Given this list of marker genes Cln6, Pum1, Serpinf1, Nr1d1, Calb1, Camk2n1, Auts2, Arrb2, Lsamp, Astn1, Shank3, Oprk1, Nms, Ins1, Kalrn, Wdr47, Crh, Aprt, Slc1a3, Abcc1, Arl6ip5, Ciart, Brsk1, Sod1, Oxr1, Calca, Sgip1, Fxr1, Lypd1, Nr1d2, Trpv1, Alb, B2m, Ager, Tpgs1, Dach1, Amfr, Lgi4, Apba2, Igf1, Taar4, Pafah1b1, Trem2, Myo15a, Prkcz, Strn, Nog (noggin), Ncor1, Slc24a2, Tafa2, Bbs12, Htra2, Nfatc4, Slc18a2, Ptger4, Eif4ebp2, Syt4 (NCBI Gene Id 20983), Slitrk5, Agtr1a, Kcnq3, Fgf2, Bsx, Avp, Nf1, Bbs1, Chat, Syngap1, Fmc1, Pak5, Shh, Sptbn2, Borcs7, Acvr2a, Prkcg, Cstb, Id2 (inhibitor of DNA binding 2), Cln3, Ncstn, Bglap2, Mir96, Camk4, Plk2, Rmi1, Scn11a, Slitrk1, Slc10a4, Kat2a, Slc17a7, Helt, Enpp1, Hexb, Fbxl20, Hrh1, Sts, Rgs14, Zfx, Adarb1, Slc1a1, Slc8a3, Lmo3, Grik1, Ephb2, Otog (NCBI Gene Id 269917), Htr1d, Adam2, Ntrk1, Lgmn, Cacna1e, Foxb1, Reg2, Dnaaf4, Pde8b, Abat, Aff2, Mc1r, Alk, Thra, Celf6, P2rx3, Npy5r, Gaa, Brinp3, Penk, Mir133a-1hg, Lep, Slc2a4, Pax5, Park7, Tal1, Adcy5, Pten, Gabrg2, Zfhx2, Pla2g6 (phospholipase A2, group VI), Klk8, Aplp2, Tacr1, Bcl2, Sgsh, Ccl11, Csnk1e, Pde5a, Etv1, Btg2 (NCBI Gene Id 98237), Chl1, Nkx2-1, Mef2c, Mecp2, Man2b1, Minar2, Ormdl1, Ptpn5, Reln, Ins2, Adrb2, Mup4, Abcc8 (ATP-binding cassette, sub-family C member 8), Mapt, Epm2a, Ctnnd2, B3gat1, Shank1, Klk14, Specc1, Negr1, Elp6, Shank2, Cln8, Fmr1, Mdga2, Cartpt, Psap, Homer2, Napepld, Nts, Glra1, Esr2, Zic1, Adcy3, Mtor, Gdf15 (NCBI Gene Id 23886), Nipal3, Gnaq, Clstn3, Mfsd2a, Ankrd26, Spire1, Grm2, Kcnd2, Nrxn1, Hand2, Axin1, Dgki (diacylglycerol kinase, iota), Hoxd10, Ghrh, Adh1, Gbx1, Neurog1, Brinp2, Casp3, Gba1, Apoe, Lonrf2, Ddhd2, Ptger3, Hmgcr, Atp6v1b1, Lrrtm1, Akt1, Pias1 (protein inhibitor of activated STAT 1), Srf, Efr3b, Git1, Cntnap2, Ubr3 (ubiquitin protein ligase E3 component n-recognin 3), Slc7a11, Rps6kb1, Cck, Slc8a2, Dbn1, Gabrb3, Pyy, Il1rn, Pak6, Hdac2, Mrgpra3, Tmbim4, Epha4, Hprt1, Homer1, Usp46, Eps8, Braf, Fzd9, Prnp, Crbn, Mme, Crebbp, Ep300, Tsc2, Ace2, Lamb1, Sez6l2, Cx3cr1, Gnb1l, Grp, Kirrel3, Foxp2, Grm7, Tac1, Septin5, Jun, Gip, En1, Insr, Cacna1b, Mfsd8, Cdk5, Iglon5, Gmppa, Npy, Adcy1, Dcdc2a, Ppp1r9b, Cxcl12, Hcrtr2, Chrna3, Adcyap1, Tmem18, Atp1a2, Atp8a2, Chrnb1, Scn1a, Gpr52, Mrap2 (NCBI Gene Id 640967), Npas1, Adora1 (NCBI Gene Id 98749), Dgat1, Qrfp, Derl2, Scn8a, Chd7, Abl1, Kmt2a, Adora2a, Pbx3, Meis2, Hcrtr1, Scn10a, Ar, Clcn3, Bcl7a, Lhx1os, Lrrn4, Pln, Oxtr (oxytocin receptor), Ncoa1, Hcn1, Aph1c, Lepr, Vps13a, Gls, Ric8a, Hif1a, Cpeb3, Zfp385a, Abtb3, Glp1r, Ttbk1, Il1b, Cacna1a, Grm1, Glud1, Gpr37, Dbh, Snap25, Cacnb4, Rogdi, Pirb, Tuba1a, Bhlhb9, Prrt1, Osm, Ntf5, Gng7 (guanine nucleotide binding protein (G protein), gamma 7), Agtr2, Gpi1, Guca2b, Ppt1, Olfm2, Gli3, Arf4, Nhlh2, Ghrl, Zzef1, Npw, Naglu, Fen1, Aaas, Ndp, Synpo, Fzd4, Tacr3, Meis1, Retn, Ube3a, Ankfn1, Cpt1a, Tifab, Dmrta1, Kcnq1, Rcan1, Prex2, Thbs4 (thrombospondin 4), Ckap5, Pax6, Vmn2r116, Aldh1a7, Dcaf11, Npb, Kcnk2, Oprl1, Tgm4, Nptx2, Dctn1, Ctns, Atp1a3, Oprd1, Pmp22, Agt, P2ry1, D130043K22Rik, Chrna4, Ahi1, Npc1, Tshr, Lrrk2, Als2, Chrnb2, Gpr171, Inpp5f, Gnat1, Ap1s2, Ift88, Per3, Crebrf, Mup20, Agrp, Lhx8 (LIM homeobox protein 8), Vps13b, Syt11, Ext1, Pirt, Drd4, Mdk, Stra6, Mrgprx1, Nlgn1, Slc22a5, Grik2, Kctd16, Ptchd1, Prlhr, Six3, Myo6, Slc6a1, Dmrt3, Chrd, Ada, Shisa7, Gabra5 (NCBI Gene Id 319559), Cic, Grin2b (glutamate receptor, ionotropic, NMDA2B (epsilon 2)), Mup5, Stat3, Kcna2, Cacna1c, Klhl1, Mta1, Ednrb, Sptbn4, Bloc1s6, Plcb1, Gpr39, Dlg4, Zfhx3, Dtnbp1 (NCBI Gene Id 94245), Nmur2, Ppp1r1b, S100b, Ptgs2, Chd8, Mc4r, Mcoln3, Atp2b2, Ndrg4, Gigyf2, Vip (vasoactive intestinal polypeptide), Fuom, Fadd (Fas associated via death domain), Glrb, Gpr176, Eif2ak4, Efnb3, Opn4, Strbp, Rag1, Gpr88, Abi2, Tanc1, Psen2, Abhd12, Rptor, Atp7a, Cc2d1a, Ttc21b, Mmp17, Drd5, Uts2r, Trpm7, Ankrd11, Rnf170, Foxa2, Dpp4, Htr2c, Jph4, Neto1, Mir23a, Slurp1, Fgfbp3, Ace, Abl2, Hdac4, Psen1, Picalm, Pcdh15, Nr4a3, Abca2, Mup1, Th, Sncg, Ube2q1, Ptprz1, Aoc3, Scn3a, Gjb4, Fosb, Vdac1, Paip2, Tlr2, Fgf14, Egr1 (early growth response 1), Fign, Itpr3, Slc4a7, Ptn, Npas3, Crhr2, Cux2, Pcm1, Trpc2, Taco1, Gfral, Pdcd10, Bbip1, Fosl1, Slc6a4, Foxo6 (forkhead box O6), Chrna5, Svs3a, Nrg1, Mafg, Adgrf1, Ppara, Bc1, Pianp, Dvl1, a, Pcdh17, Myo5a, Pgr, Comt, Hoxd9, Grm6, Hcrt, Grcc10, Pex13, Gad1, Musk, Pde4d, Unc79, Cyp11b2, Oprm1 (opioid receptor, mu 1), Sct (NCBI Gene Id 20287), Atp1b2, 2510009E07Rik, Rxfp4, Dmbx1, Egr2, Slc16a1, Creb1, Sez6, Rapgef3, Kat2b, Pja2, Idua, Scn9a, Gprin3, Vps54, Pmch, Trmt1l, Etv5, Cort, Mup3, Agtpbp1, Nrxn3, Asic4, Cntn1, Pfkfb3, Rin1, Drd1, Ldlr, Nr4a2, Gria1, Dbi, Agrn, Trp53, Gm2990, Nav2, Dkk1, P2rx4, Kcnq2, Sez6l, Iapp, Slc1a2, Dmd, Apba1, Rnf180, Vps35, Grin1, Adcy8, Clstn2, Aph1b, Ntan1, Itga5, Ptgs1, Csf2, Crhbp, Adam22, Nrxn2, Dnah11, Vwa1, Tmem74, Ntsr1, B4galnt1, Cntfr, P2rx2, Eif4g1, Hoxa1, Aldh1a3, Kcnj10, Trpm4, Fkrp, Csmd1, Gm527, Grid1, Aim2, Gla, Ncoa2, Sdk1, Ahcyl, Nps, Ddo, Slc25a46, Gfi1, Tmod1, Pou4f1, Gucy2d, Itgb1, Ido1, Selenop, Cdh23, Fgf13, Snca, Adm2, Insl5, Prlh, Npy2r, Cfap20, Vdac3, Nr3c1, Grin2d, Uba6, Gcnt4, Gnao1, Parp1, Nlgn3, Lmx1a, Pde1b, Kras, Nlgn2, Nptn, Aldh2, Abca7, Nr2e1, Npas4, Nedd9, Gpr83, Ntrk2, Apln, Abcb1b, Mup2, Runx1, Ift20, Slc4a10, Mup11, Fshr, Hexa, Atxn1l, Pitx3, Slc12a5, Dab1 (disabled 1), Uchl1, Bbs4, Casp1 (NCBI Gene Id 12362), Esp22, Fezf2, Grn, Lcn2, Dynlrb1, Jph3, Npy1r, Eif4e, Fig4, Adrb1, Adra1b, Ngf, Rcan2, Grm4, Deaf1, Htt, Col6a1, Ccnd2, P2rx1, Git2, Bglap, Npsr1, Prkaa1, Cnp, Cnr1, Cyp11a1, Bace1, Serpine2, Thbs1, Hrh3, Ahcy, Tmod2, Ghsr, Spg21 (SPG21, maspardin), Capn2, Srpx2 (sushi-repeat-containing protein, X-linked 2), Tsx, Bdnf, Atg7, Ncam1, Asic1, Slitrk6, Atp8a1, Wfs1, Bahcc1, Chrna7, Cckar, Tpbg (trophoblast glycoprotein), Baiap3, Ndufs4, Bche, Tnr, Cntnap4, Morc1, Phf21a, Nos1, Tbr1, App, Sod2, P2ry2, Prkar1b, Ptgds, Grm5, Zmpste24, Gal, Cend1, Prl, Dscam, Cntn2, Nlgn4l, Itga3 (NCBI Gene Id 16400), Esp1, Sorcs3, Oxt, Crhr1, Kcnab1, Prkn, Met, Acss2, Synj1, Kit, Myh14 (NCBI Gene Id 71960), Cyp7b1, Htr6, Ghrhr, Drd2, Ythdf1, Mbd5, Htr2b, Sobp (NCBI Gene Id 78400), Taar5, Nmu (NCBI Gene Id 56183), Kcnip3, Ren1, Fxn, Ppy, Hoxb8, Cwh43, Celsr1, Atxn3, Htr7, Ucn, Fto, Pgrmc1, Crtc1, Gpr157, Tspo (translocator protein), Ceacam2, Itga8, Gng8, Lpar5, Gnat2, Prkca, Slc6a3, Fos, Ulk4, Myg1, Adgrl3, Chrna6, Chrnb4, Pak1, Zdhhc8, Cfap69 (cilia and flagella associated protein 69), Ttc36, Egfr, Espn, Hipk2, Gprc5b, B4galt2, Arrdc3, Uchl3, Prkar2b, Slc24a4, Mapk8ip2, Npas2, Adgrb3, Brinp1, Btbd9, Tacr2, Igf2, Grpr, Mbd2 (methyl-CpG binding domain protein 2), Trh (thyrotropin releasing hormone), Amph, Fev, Fgf12, Gja1, Cckbr, Ppp3cb, Nr3c2, Adnp, Mc3r, Hrh2, Gatm, Htr1a, Foxp1, Nr2c2, Chst10, Tbx1, Grin2a, Slc11a2, C1ql1, Garem2, Map1a, Avpr1a, Uts2, Tbce, Sgk1, Neurod2, Elavl4, Zfp212, Bbs2, Spg11, Nfix, Mapk10, Slitrk4, Arc, Scn2a, Asl, Gmfb, Src, Thrb, Atad1, Drd3, Rasd2, Agtr1b (angiotensin II receptor, type 1b), Mkks, Ehmt2, Htr1b, Adrb3, Prkce, Shc3, Ormdl3, Mchr1, Pomk (NCBI Gene Id 74653), Gm2a, Tsc1, Adam11, Il6, Mtnr1b (NCBI Gene Id 244701), Large1, C1qtnf4, Atxn1, Arcn1, Kcnma1 (potassium large conductance calcium-activated channel, subfamily M, alpha member 1), Usp2, Htr2a, Lmx1b, here is a description of the gene set: The internally coordinated responses (actions or inactions) of animals (individuals or groups) to internal or external stimuli, via a mechanism that involves nervous system activity. studied in species Mus musculus Mouse Gene Set: GOBP_BEHAVIOR